The following is a description of a gene set: Genes predicted to be targets of miRBase v22 microRNA mmu_miR_1951 in miRDB v6.0 with MirTarget v4 prediction scores > 80 (high confidence targets). studied in species Mus musculus Mouse Gene Set: MIR_1951 from publication Chen Y, Wang X (PMID 31504780), and this is the list of marker genes: Plpp3, Ptges3, Ryr2, Il1rap, Fabp4, Nol4, Wdfy3, Cldn19, Cd209b, Krtap5-5, Sash3, Ccnj, Dcaf12l1, Krtap4-2, 1700006A11Rik, Katnbl1, Senp7, Pdk3, Mmd, Cd9, Dzip3, Cd38, Vegfc, Steap2, Fgb, Elp6, Rad51b, 2310030G06Rik, Chl1, Plec, Dcun1d3, Cdh12, Lama3, Marf1, Slc15a2, Dido1